The following is a description of a gene set: species: Homo sapiens Affymetrix U133plus2 GeneChips were used to profile 59 head and neck squamous cell cancers. A hypoxia metagene was obtained by analysis of genes whose in vivo expression clustered with the expression of 10 well-known hypoxia-regulated genes (e.g., CA9, GLUT1, and VEGF). To minimize random aggregation, strongly correlated up-regulated genes appearing in >50% of clusters defined a signature comprising genes, of which 27% were previously known to be hypoxia associated. The median RNA expression of the genes in the signature was an independent prognostic factor for recurrence-free survival in a publicly available head and neck cancer data set, outdoing the original intrinsic classifier. In a published breast cancer series, the hypoxia signature was a significant prognostic factor for overall survival independent of clinicopathologic risk factors and a trained profile. The work highlights the validity and potential of using data from analysis of in vitro stress pathways for deriving a biological metagene/gene signature in vivo. from publication Winter SC, Buffa FM, Silva P, Miller C, Valentine HR, Turley H, Shah KA, Cox GJ, Corbridge RJ, Homer JJ, Musgrove B, Slevin N, Sloan P, Price P, West CM, Harris AL (PMID 17409455) Human Gene Set: WINTER_HYPOXIA_UP Genes up-regulated in head and neck tumor samples which clustered around known hypoxia genes., and this is the list of marker genes: AK4, RAN, PPP4R1, ANKRD37, RNPS1, ANKRD9, SNX24, MRPL14, HOMER1, RHOC, PGF, ANGPTL4, TEAD4, CNIH4, PTGFRN, DPM2, BCAR1, HES2, SLC2A1, TMTC3, CXCL8, PSMD2, NUDT15, VAPB, SLC6A8, ADORA2B, S100A3 (S100 calcium binding protein A3), GEMIN2, PFKFB4, NME1, BMS1, NTMT1, TPI1, HAUS2, HILPDA, CDCA4, TRMT5, MNAT1, EEF1AKMT4 (EEF1A lysine methyltransferase 4), ALDOA, P4HA1, SLIRP, TPD52L2, LDHA, XPO5, VEGFA, LDLR, NDUFA4L2, TMEM30B, METTL22, MTX1, GAPDH, PVR, TPBG, COL4A5, KCTD11, IGF2BP2, PGK1, B4GALT2, S100A10 (S100 calcium binding protein A10), VEZT, GPN3, RUVBL2, BNIP3, PAWR, TFAP2C, PEDS1, PYGL, SLCO1B3, C16orf74, PLEKHG3, CA9, PDZD11, PPARD, MRGBP, KRT17, NDRG1, TNS4, CA12, GSS, PGAM1, EIF2S1, MIF, ANLN, CORO1C, RNF24, MRPS17, PSMA7, PLAU, SLC16A1, TANC2, PSMB7, GMFB, TIMM23, TUBB4B